The following is a description of a gene set: Human Gene Set: GAUSSMANN_MLL_AF4_FUSION_TARGETS_F_UP The reciprocal chromosomal translocation t(4;11) is correlated with infant, childhood, adult and therapy-related high-risk acute leukemia. Here, we investigated the biological effects of MLL.AF4, AF4.MLL or the combination of both reciprocal fusion proteins in a conditional in vitro cell culture model system. Several parameters like cell growth, cell cycling capacity, apoptotic behavior and growth transformation were investigated under physiological and stress conditions. Co-transfected cells displayed the highest resistance against apoptotic triggers, cell cycling capacity and loss-of-contact inhibition. These analyses were complemented by gene expression profiling experiments and specific gene signatures were established for each of the three cell lines. Interestingly, co-transfected cells strongly upregulate the homeobox gene Nanog. In combination with Oct4, the Nanog homeoprotein is steering maintenance of pluripotency and self-renewal in embryonic stem cells. Transcription of Nanog and other stem cell factors, like Oct4 and Bmi1, was verified in biopsy material of t(4;11) patient cells which express both reciprocal t(4;11) fusion genes. In conclusion, the presence of both reciprocal MLL fusion proteins confers biological properties known from t(4;11) leukemia, suggesting that each of the two fusion proteins contribute specific properties and, in combination, also synergistic effects to the leukemic phenotype. studied in species Mus musculus Up-regualted genes from the set F (Fig. 5a): specific signature shared by cells expressing AF4-MLL alone and those expressing both AF4-MLL and MLL-AF4 fusion proteins. from publication Gaussmann A, Wenger T, Eberle I, Bursen A, Bracharz S, Herr I, Dingermann T, Marschalek R (PMID 17130830), and this is the list of marker genes: H1-2 (NCBI Gene Id 3006), PCDHB18P, SERPINB1, MEG3, TMEM141, ADAMTSL4, PCID2, SERF1A, OTOR, H2BC4, C1QTNF1, CNN1, OPTC, CSAD, CX3CL1, GSTT1, CLMN, MAP3K8, ADAMTS2, ISG15, FMOD, ZNF185, CACNA1G, PLCE1, NUAK1, GAS6, GSTM1, TMEM176B, CEBPD, PSTPIP2, ARHGAP28, TMEM154, LY6E, ABLIM1, BMP4 (bone morphogenetic protein 4), PCDHB15, PLSCR1, FGF5, COL6A1, TCP11L2, ARHGEF3, ACTG2, DYSF, AFAP1L2, RNF150, LTBP2, SPRY1, FBLN1, PRRC2C, STING1, GM2A, MFAP5, JARID2, CAST, RRAD, PIK3IP1 (phosphoinositide-3-kinase interacting protein 1), EGFR, RCBTB2, LGALS9, ZFAND5, RBM26, GAS1, TDRD3, OR51B2, ZNF398, SYNPO, SPPL2A (NCBI Gene Id 84888), LOX, LGALS3BP, WNK2, NPR3, LIFR, ECM1 (extracellular matrix protein 1), ADGRG6, OSMR, HS6ST2 (NCBI Gene Id 90161), CDA, PREX2, OLFML3, IL4R, FCGRT, NDRG4, TLE2, DNASE2, NCKAP5, DKK3, ZFP36L1, S100A16, KIAA1671, PNRC1, IFIH1, PLXDC2, LHX9, CARD10, CNP, IFI44, ENTREP3, DAB2, FAM43A, IFT70B, F2RL1, PLAT, EMILIN2, KDM7A, COL3A1, IL18, LDB3, AHR, LRRCC1, SCN3A, PRICKLE1, EPHA4, SSBP4, FEZ1, PDGFB, NFKBIZ, SDF4, BHLHE22, TMEM176A, LMO7, TGFB3 (transforming growth factor beta 3), RGS4, TP53INP1 (NCBI Gene Id 94241), PCTP, CTSH, BTN1A1, TMEM30A, NT5E, TTLL7, RSRP1, SYNM, MME, EPN3, TNFRSF11B, ST3GAL5, DECR1, SLC16A4, ADAMTS4, NR4A3, OSR1, SCARA3, AUTS2, ECHDC2, CASP12, PLAC9, ARSB, S100A13, COL6A2, CLIP4, ADGRL3 (NCBI Gene Id 23284), KLHL30, TLR1, PLEKHA6, IL17RD, ATP8B4, TOX, ARFGAP3, MATN2, NSD1, HNRNPA3, SLC7A2, MFAP2, L3HYPDH, PCNX1, FST, PIBF1, SELENOP, C1orf54, SNTA1, PTP4A3, FBLN7, MAPK12, GPC4, BMPER, GJB3, OGN, TEK, PIR, BTG2, PLCG2, ENY2, CDHR4, SLC1A3, DRAM1